Given this list of marker genes LMBRD2 (NCBI Gene Id 92255), SKP2, COQ8B, GINS4, ITPKC, ZNF546, here is a description of the gene set: Human Gene Set: ZNF20_TARGET_GENES from publication Yevshin I, Sharipov R, Kolmykov S, Kondrakhin Y, Kolpakov F (PMID 30445619) Genes containing one or more binding sites for (ZNF20) in their promoter regions (TSS -1000,+100 bp) as identified by GTRD version 20.06 ChIP-seq harmonization. studied in species Homo sapiens